The following is a description of a gene set: studied in species Mus musculus Reactome Pathway: Chaperonin-mediated protein folding electronically inferred by orthology from the curated human pathway This event has been computationally inferred from an event that has been demonstrated in another species.<p>The inference is based on the homology mapping from PANTHER. Briefly, reactions for which all involved PhysicalEntities (in input, output and catalyst) have a mapped orthologue/paralogue (for complexes at least 75% of components must have a mapping) are inferred to the other species. part of: Protein folding, and this is the list of marker genes: Gna14, Cct5, Cct8, Rgs7, Gng10, Gnb3, Gnb2, Gng4, Rgs6, Rgs9, Gnb5, Cct3, Gng11, Cct2, Cct6b, Gng3, Gngt2, Cct6a, Gngt1, Gng8, Csnk2b, Cct7, Gng5, Gng7